Given this list of marker genes ADA, CNOT1, SP3, JUNB, BYSL, CUL3, HAND1, CTR9, EOMES, RBM46, NODAL, YAP1, CNOT2, CNOT3 (NCBI Gene Id 9756), TFAP2C, CDX2 (caudal type homeobox 2), SRF, TEAD4, CITED2, HOPX, here is a description of the gene set: Human Gene Set: GOBP_TROPHECTODERMAL_CELL_DIFFERENTIATION species: Homo sapiens The process in which a relatively unspecialized cell acquires the specialized features of a trophectoderm cell.